The following is a description of a gene set: A loss or impairment of the sensation of the relative position of parts of the body and joint position occurring at distal joints. Human Gene Set: HP_IMPAIRED_DISTAL_PROPRIOCEPTION Impaired distal proprioception species: Homo sapiens, and this is the list of marker genes: POLG, CYP7B1, MTTP, MPV17, RNF170, POLR3B, XRCC1, KIF1A, DARS2, MORC2, BSCL2, GDAP1, NDRG1, SPTLC1, PDYN, POLR3A, TWNK, TDP1